Given this list of marker genes Klf6, Fos, Hspa1b, Jun, Tsc22d3, Uba52, Hspa1a, here is a description of the gene set: Genes negatively differentially expressed in cell type: CD8+ T cell upon treatment with cytokine: IL-Y in mouse lymph nodes in vivo. Mouse Gene Set: CUI_T_CELL_CD8_IL_Y_RESPONSE_DN Cytokines mediate cell-cell communication in the immune system and represent important therapeutic targets. A myriad of studies have highlighted their central role in immune function, yet we lack a global view of the cellular responses of each immune cell type to each cytokine. To address this gap, the authors created the Immune Dictionary, a compendium of single-cell transcriptomic profiles of more than 17 immune cell types in response to each of 86 cytokines (>1,400 cytokine-cell type combinations) in mouse lymph nodes in vivo. A cytokine-centric view of the dictionary revealed that most cytokines induce highly cell-type-specific responses. For example, the inflammatory cytokine interleukin-1β induces distinct gene programmes in almost every cell type. A cell-type-centric view of the dictionary identified more than 66 cytokine-driven cellular polarization states across immune cell types, including previously uncharacterized states such as an interleukin-18-induced polyfunctional natural killer cell state. species: Mus musculus from publication Cui A, Huang T, Li S, Ma A, Pérez JL, Sander C, Keskin DB, Wu CJ, Fraenkel E, Hacohen N (PMID 38057668)